Given this list of marker genes SOX18, ELN, COL5A1, COL1A2, ALDH18A1, CTC1, FOCAD, TGFBR2, ZMPSTE24, COL1A1, B3GALT6, LMNA (lamin A/C), TWIST2, PYCR1, CHD1, FBLN5, EFEMP1, FILIP1, COL3A1, IARS1, PPP1CB, POLR3A, EFEMP2, SLC25A24, SMAD2, ADAMTS2, SMAD3, TGFBR1, here is a description of the gene set: An abnormally increased ability of the skin to permit light to pass through (translucency) such that subcutaneous structures such as veins display an increased degree of visibility. Dermal translucency species: Homo sapiens Human Gene Set: HP_DERMAL_TRANSLUCENCY